The following is a description of a gene set: species: Mus musculus Gene expression in the gut is segmentally regulated, but little is known of the molecular origin of patterning. Analysis of gene expression in colons from mice lacking the methyl-CpG binding repressor MBD2 revealed frequent activation of genes that are normally only expressed in the exocrine pancreas and duodenum. Reduced DNA methylation activated the same gene set in the colon. No significant differences in DNA methylation between the colon and duodenum were detected, but MBD2 was significantly more abundant in the colon. The relevance of MBD2 concentration was tested in a human colon cancer cell line. Depletion of MBD2 was again found to activate exocrine pancreatic genes. Gene activation in this cell culture model was accompanied by loss of promoter-bound MBD2 and increased histone acetylation. The results suggest that modulation of MBD2 during gut development establishes a region-specific gene expression pattern that is essential for establishing correct segmental character. from publication Berger J, Sansom O, Clarke A, Bird A (PMID 17353267) Human Gene Set: BERGER_MBD2_TARGETS Genes strongly up-regulated in colon tissue upon MBD2 knockout., and this is the list of marker genes: TFF2, CELA2A, PRSS2, RNASE1, CEL